The following is a description of a gene set: studied in species Homo sapiens Human Gene Set: chr21p12, and this is the list of marker genes: ENSG00000280191, LOC102724701, LINC01670, ENSG00000275464, hsa-mir-8069-1, ENSG00000275895, ENSG00000277117, ENSG00000274559, ENSG00000278903, ENSG00000280433, ENSG00000274276, ENSG00000275993 (novel protein, similar to salt-inducible kinase 1 SIK1), LINC03104 (long intergenic non-protein coding RNA 3104), ENSG00000276076, ENSG00000280018, ENSG00000280071